The following is a description of a gene set: Human Gene Set: HP_CARDIAC_DIVERTICULUM Cardiac diverticulum studied in species Homo sapiens A cardiac diverticulum is a rare congenital malformation which is either fibrous or muscular., and this is the list of marker genes: CHEK2, TGFBR2, MLH1, ATM, SEMA4A, RPS20, PMS1, PIK3CA, KRAS, MUTYH, BRCA2, MSH6, BMPR1A, PMS2, POLD1, MSH2, EPCAM, POLE